Given this list of marker genes RPGRIP1L, GBF1, RAB11A, TUBA1B, CEP63, SEPTIN2, HAUS7, RP2, DCTN1, CPAP, CEP192, AHI1, TMEM216 (NCBI Gene Id 51259), HAUS5, PAFAH1B1, IFT80, DYNC1I2, EXOC6, DYNC2LI1, CEP78, TMEM67, TCTN1, HAUS6, KIF17, BBS10, KIF3A, DYNC2H1, CEP135, MCHR1, TUBG1, TUBA3E, EXOC8, ARF4, CLASP1, TRIP11, WDR19, PLK1, DYNLT2B, OFD1 (NCBI Gene Id 8481), TTBK2, CCT4, TUBB4B, TCTN3, DCTN3, EXOC1, CCT2, SDCCAG8, DYNC1H1, ACTR1A, SCLT1, CC2D2A, ATAT1 (alpha tubulin acetyltransferase 1), CEP43, CNGA4, RAB11FIP3, CKAP5, TUBA1A, EXOC7, CEP97, CDK5RAP2, TUBB2B, ALMS1, BBS4, CSNK1D, FBF1, NPHP4, IFT56, AKAP9, TTC21B, HAUS1, CNGB1, CEP164, CEP57, YWHAG, IFT57, IFT20, DYNLL1, PRKACA, NINL, CEP70, RAB8A (RAB8A, member RAS oncogene family), BBS2, CEP162, HAUS3, TCTN2, PRKAR2B, RHO, TTC8, CETN2, IFT70A, TUBB2A, CLUAP1, ARL13B, HAUS2, IFT70B, HAUS8, ASAP1, CCT3, MKKS, PPP2R1A, ARL6, IQCB1, HSP90AA1 (NCBI Gene Id 89272), CCT5, ARL3, BBS7, MKS1, TUBA1C, PCM1, NEDD1, MARK4, BBS1, MAPRE1, IFT140, KIF3B, DCTN2, IFT52, IFT43, DYNC2I1, KIF3C, BBS5, TUBB3, B9D2, IFT172, CEP152, CNTRL, TNPO1, CCP110, B9D1, SMO, TUBA3C, BBIP1, TUBB8, CEP131, DYNLT5, TUBB8B, KIFAP3, CEP290, CCT8, PKD2, RAB3IP, TRAF3IP1, IFT27, CEP83, HAUS4, ODF2 (outer dense fiber of sperm tails 2), CEP89, EXOC2, HDAC6, NPHP3, TCP1, IFT81, CEP76, DYNLRB1, TUBB6, DYNC2I2, LZTFL1, TUBB, TUBB1, TUBB4A, SFI1 (NCBI Gene Id 9814), PKD1, PDE6D, CEP250, SSTR3, EXOC5, SSNA1, CYS1, EXOC3, IFT46, C2CD3, KIF24, NPHP1, DYNLRB2, YWHAE, PLK4, CNGA2, DYNLT2, IFT25, TUBA8, IFT88 (intraflagellar transport 88), BBS12, CEP41, PCNT, WDR35, CEP72, TUBAL3, IFT74, UNC119B, CDK1, IFT22, BBS9, DYNLL2, IFT122, TUBA4A, EXOC4, INPP5E, NEK2, TUBA3D (tubulin alpha 3d), CSNK1E, NDE1, here is a description of the gene set: part of: Cilium Assembly This pathway describes primary cilium formation. The primary cilium is a sensory organelle that is required for the transduction of numerous external signals such as growth factors, hormones and morphogens, and an intact primary cilium is needed for signaling pathways mediated by Hh, WNT, calcium, G-protein coupled receptors and receptor tyrosine kinases, among others. Unlike the motile cilia, which are generally present in large numbers on epithelial cells and are responsible for sensory function as well as wave-like beating motions, the primary cilium is a non-motile sensory organelle that is present in a single copy at the apical surface of most quiescent cells. The primary cilium is a dynamic structure that undergoes continuous steady-state turnover of tubulin at the tip; as a consequence, the IFT machinery is required for cilium maintenance as well as biogenesis. Reactome Pathway: Assembly of the 9+0 primary cilium studied in species Homo sapiens